The following is a description of a gene set: species: Homo sapiens Human Gene Set: MIR4717_3P from publication Chen Y, Wang X (PMID 31504780) Genes predicted to be targets of miRBase v22 microRNA hsa-miR-4717-3p in miRDB v6.0 with MirTarget v4 prediction scores > 80 (high confidence targets)., and this is the list of marker genes: SERTM1, SNAI2, COLGALT2, EEIG2, PPP1R12A, PKD2, MEGF10, PSME3, KLHL14, WDR26, TUBA1B, METTL2A, EML4 (NCBI Gene Id 54548), MRPL50, FSHR, ARL8B, GRK5, GRB14, CGGBP1, MYH3, PPP1R8, ZNF24, ZNF124 (NCBI Gene Id 7678), COL21A1, C1QL3, NIPSNAP2, POP1, RASSF3, SASH1, FAM151B, KLHL24, ROBO1, HS3ST2, LIN54, DDN, TMEFF1, SPHKAP, CLOCK, RNASE9, PUM2, BAZ2A, EML6 (NCBI Gene Id 649652), ADGRF1, MACROH2A2, ZDHHC23, DCUN1D5, SUMF1, ING2, ZNF451, KIAA1191, ERLIN1, ZNF48, GPR65, RORA, NDP, ZFHX4, SYNJ1, MSANTD3-TMEFF1, CAMK4, PPEF2, SCML4, BEX3, RASGEF1B, TGIF1, TNPO1, STC1, AFF3, PLEKHA2, KHDRBS2, METTL2B, WASF1, PRKD3, KLHDC2, CELF2, CREM, RIN2